Given this list of marker genes Itpripl1, Klf4, Ckb, Hspa1b, Atp5me, Tsc22d3, Klf2, Uba52, Jun, Lyz2, Hspa1a, Kctd12, here is a description of the gene set: Mouse Gene Set: CUI_CDC1_IFNE_RESPONSE_DN species: Mus musculus Genes negatively differentially expressed in cell type: cDC1 (conventional dendritic cell type 1) upon treatment with cytokine: IFN-ε in mouse lymph nodes in vivo. from publication Cui A, Huang T, Li S, Ma A, Pérez JL, Sander C, Keskin DB, Wu CJ, Fraenkel E, Hacohen N (PMID 38057668) Cytokines mediate cell-cell communication in the immune system and represent important therapeutic targets. A myriad of studies have highlighted their central role in immune function, yet we lack a global view of the cellular responses of each immune cell type to each cytokine. To address this gap, the authors created the Immune Dictionary, a compendium of single-cell transcriptomic profiles of more than 17 immune cell types in response to each of 86 cytokines (>1,400 cytokine-cell type combinations) in mouse lymph nodes in vivo. A cytokine-centric view of the dictionary revealed that most cytokines induce highly cell-type-specific responses. For example, the inflammatory cytokine interleukin-1β induces distinct gene programmes in almost every cell type. A cell-type-centric view of the dictionary identified more than 66 cytokine-driven cellular polarization states across immune cell types, including previously uncharacterized states such as an interleukin-18-induced polyfunctional natural killer cell state.